The following is a description of a gene set: Wasting of the pectoral muscles, i.e., of the pectoralis major and pectoralis minor. This finding is often manifested by prominent axillary creases or double axillary creases. studied in species Homo sapiens Pectoralis amyotrophy Human Gene Set: HP_PECTORALIS_AMYOTROPHY, and this is the list of marker genes: DUX4, SMCHD1, CAPN3, DUX4L1, DNMT3B, FRG1